Given this list of marker genes Crlf3, Esyt2, Cd74, Smc4, Il7r, Hspa1b, Hspa1a, Satb1, Smc6, Gramd1a, Tcf7, Selenop, here is a description of the gene set: from publication Cui A, Huang T, Li S, Ma A, Pérez JL, Sander C, Keskin DB, Wu CJ, Fraenkel E, Hacohen N (PMID 38057668) Mouse Gene Set: CUI_T_CELL_CD4_TSLP_RESPONSE_DN studied in species Mus musculus Genes negatively differentially expressed in cell type: CD4+ T cell upon treatment with cytokine: TSLP in mouse lymph nodes in vivo. Cytokines mediate cell-cell communication in the immune system and represent important therapeutic targets. A myriad of studies have highlighted their central role in immune function, yet we lack a global view of the cellular responses of each immune cell type to each cytokine. To address this gap, the authors created the Immune Dictionary, a compendium of single-cell transcriptomic profiles of more than 17 immune cell types in response to each of 86 cytokines (>1,400 cytokine-cell type combinations) in mouse lymph nodes in vivo. A cytokine-centric view of the dictionary revealed that most cytokines induce highly cell-type-specific responses. For example, the inflammatory cytokine interleukin-1β induces distinct gene programmes in almost every cell type. A cell-type-centric view of the dictionary identified more than 66 cytokine-driven cellular polarization states across immune cell types, including previously uncharacterized states such as an interleukin-18-induced polyfunctional natural killer cell state.